The following is a description of a gene set: studied in species Homo sapiens Reactome Pathway: InlA-mediated entry of Listeria monocytogenes into host cells part of: Listeria monocytogenes entry into host cells The pathogenic bacteria Listeria monocytogenes can enter host cells through endocytosis triggered by binding of the bacterial cell wall protein internalin (InlA) to the E-cadherin (CDH1) complex at the host cell plasma membrane. Binding of InlA to CDH1, similar to CDH1 engagement during normal cell-to-cell adhesion, triggers activation of the SRC protein tyrosine kinase and phosphorylation of CDH1 and CDH1-bound beta-catenin (CTNNB1). Integrins likely contribute to CDH1-triggered SRC activation, and ERKs (MAPK1 and MAPK3), ROCKs and MLCK may also be involved. FAK1 (PTK2), a SRC-regulated protein tyrosine kinase, may contribute to SRC-mediated regulation of CDH1.<br>Phosphorylation of CDH1 and CTNNB1 by SRC creates docking sites for a CBL-like ubiquitin protein ligase Hakai (CBLL1). CBLL1 ubiquitinates SRC-phosphorylated CDH1 and CTNNB1 upon InlA binding, as well as in the context of CDH1-mediated cell-to-cell adhesion, thus triggering CDH1 endocytosis.<br>CBLL1 may also undergo SRC-mediated phosphorylation and subsequent autoubiquitination.<br>Both clathrin-mediated and caveolin-mediated endocytosis are implicated in the InlA-mediated entry of Listeria monocytogenes to host cells. SRC-mediated phosphorylation of cortactin and the ARP2/3 complex involved in actin polymerization is implicated in CDH1 endocytosis and Listeria monocytogenes internalization., and this is the list of marker genes: inlA, RPS27A, CDH1, SRC, UBB, CBLL1, UBC, UBA52, CTNNB1, CTNND1